Given this list of marker genes Ctnnd1, Xbp1, Muc19, Nfib, Clcn2, here is a description of the gene set: Mouse Gene Set: GOBP_CELL_DIFFERENTIATION_INVOLVED_IN_SALIVARY_GLAND_DEVELOPMENT species: Mus musculus The process in which a relatively unspecialized cell acquires specialized structural and/or functional features that characterize the cells of the salivary gland.